Given this list of marker genes Ubb, Rps27a, here is a description of the gene set: Reactome Pathway: ER Quality Control Compartment (ERQC) electronically inferred by orthology from the curated human pathway studied in species Mus musculus part of: Calnexin/calreticulin cycle This event has been computationally inferred from an event that has been demonstrated in another species.<p>The inference is based on the homology mapping from PANTHER. Briefly, reactions for which all involved PhysicalEntities (in input, output and catalyst) have a mapped orthologue/paralogue (for complexes at least 75% of components must have a mapping) are inferred to the other species.